The following is a description of a gene set: The presence of skeletal muscular atrophy (which is also known as amyotrophy). studied in species Homo sapiens Human Gene Set: HP_SKELETAL_MUSCLE_ATROPHY Skeletal muscle atrophy, and this is the list of marker genes: POLR3A, NDE1, FLVCR1, ACADM, CAV3, MINPP1, ACTB, DHTKD1, OPA1, POMK, COL6A3 (collagen type VI alpha 3 chain), MYH3, JAG2, FOXP2, BMP1, CEP126, MKKS, PMP22, RBCK1, NPHP1, AMPD2, COG8, HSPB1, CHP1, COL2A1, MT-TE, ERGIC1, PYGM, SCO2, CRPPA, CD59, PHYH, C2orf69, DNM2, AGRN, SH3TC2, SIL1, TBK1, STUB1, BBS7, GYG1, TP53, SBF1, TOE1, MFN2, RNF170, ATAD3A, RNF31, CHRNG, VLDLR, MSTO1, TPM2, LZTFL1, SCAPER, ADSL, ERBB4, HNRNPA1, KIF5A, TBC1D23, SCN4A, KIF1B, BBS12, HK1, GBE1, IDUA, ITPR1, ADK, ARL6, SCYL1, PSMG2, WRN, IFT74, MARS1 (NCBI Gene Id 4141), TTC19, ADSS1, MLIP, MAFB, CADM3, HEXB, GNE, TPI1, MGME1 (NCBI Gene Id 92667), DARS2, WDR81, PLEKHG5, PHKB, PEX7, BBS4, ERLIN1, COMP, ADARB1, TUBB2B, SUCLG1, AR, TBCK, MYH7, SQSTM1, CHRND, BRAF (NCBI Gene Id 673), SLC9A6, CCT5, WNK1, NALCN, NDUFA9, ARSI, CPT1A, PGAP1, SMN2, NBN, SPAST, ITPR3, AK9, ANTXR2, MAG, RXYLT1, MT-ATP8, UNC13A, YY1, ATL3, CHMP2B, ITGA7, SFXN4, MEGF10, UNC45B, ATP8A2, CARS1, LAMB2, DNAJC19, MST1, NDUFA8, KLC2, DHH, SDHD (NCBI Gene Id 91899), PHF6, FHL1, BBS10, NEFH, TIA1, SMCHD1, PHKA1, TCAP, PON1 (paraoxonase 1), ANO5, DMD, WASHC5, IBA57, CYP27A1, VAMP1, CA8, CNTNAP1, MYH14, SDHAF1, RETREG1, PEX5, JPH1, SOX10, REV3L, TRIM2, SDHB, WARS1, DAG1, LIMS2, NEMF (NCBI Gene Id 9147), GIPC1, LMOD3, TRPV4, PYROXD1, NT5C2, SYNE1, SLC46A1, B4GALT7, B4GALNT1, COL6A2, INPP5K, OGDH, OPTN (NCBI Gene Id 337928), DCAF8, DAO, CHRNA1, KRT14, NOTCH2NLC, COL6A1, FLNA, PRPH, SYT2, TOR1AIP1, DNM1L, CEP290, PIP5K1C, FIG4, MYO9A, ATP13A2, IGHMBP2, RAB7A (RAB7A, member RAS oncogene family), MYMK, B3GALNT2 (NCBI Gene Id 148789), NAGA (NCBI Gene Id 4668), PAX3, CDH23, SVBP, BBS1, SNAP25, SLC25A19, FLRT1, FBXL4, DYNC1H1, TIMMDC1, EXOSC3, KDM5C (NCBI Gene Id 8242), MTMR14, RECQL, COLQ, SETX, AFG3L2, BAG3, CD28, ERLIN2, KAT6A, INF2, TFG, COQ2, H4C11, VRK1, TMTC3, TRAPPC11, ATXN2, POLG, CTLA4, LMNA, MTRFR, DOK7 (docking protein 7), POGLUT1, NR3C1, KLHL40, AIFM1, POLRMT, COQ7, B4GAT1, AIMP1, TYMP, NDUFB8, VWA1, CHRNB1, ACTA1, GLT8D1, PON3, VAPB, SLC33A1, CHAT, ZFYVE26, BMP4, FUCA1, PMP2, DPM3 (NCBI Gene Id 54344), COL12A1, SPRTN, SLC52A3, NARS2, MUSK, ASCC1, ERCC6, SDCCAG8 (NCBI Gene Id 10806), ADCY6, FBLN5, SLC5A6, HINT1, KLHL41, SIGMAR1, CPT1C, MPZ, DALRD3, VPS13A, GLE1, VMA21, MRE11, MORC2, CAPN1, BBS2, CUL4B (cullin 4B), GALC, PLXND1, SEMA4D, GAN, ANG, AARS1, TARDBP (TAR DNA binding protein), NUP88 (NCBI Gene Id 4927), SLC25A21, TREM2, PAX7, CHCHD10, PTEN, CNBP, EXOSC9, PUS1, SLC52A2, NEB, SYNE2, SCN5A, SOD1, TNFRSF1B, MME, WDPCP, SALL4, SGCD, RRM2B, SLC39A13, ACADSB, HMGA2, FXN, SGCG, BBIP1, SUCLA2, KDM1A, JAG1, ACTN2, HARS1 (histidyl-tRNA synthetase 1), NIPA1, KRT5, HYCC1, KY, VPS13D, BSCL2, SPART, MYBPC1, SMN1 (NCBI Gene Id 91918), BIN1, CFAP418, POMGNT1, PEX6, SPTBN4, BBS9, ATP1A1, UBAP2L, RILPL1, KBTBD13, MDH2, RAI1, SCYL2, ATP7A, MCCC2, PHKA2, CHN1, ATXN1, HSPB3, SCLT1, TNXB, MTAP, POMT2, LRP12, PFKM, MYMX, MPV17, PIK3R5, ERBB3, PIEZO2, MYOT, PRX, AP1S2 (adaptor related protein complex 1 subunit sigma 2), SLC18A3 (solute carrier family 18 member A3), VCP, NPPA, ASAH1, GJB1, DYSF, DUX4L1, AGTPBP1, UBAP1, NOP56, DUX4, AMPD1, STAT1, MT-TL1, ADAMTS15, CTNS (cystinosin, lysosomal cystine transporter), UBA1, TMEM43, POMT1, CFAP410, PDK3, PNPT1, PIGA, ATCAY (NCBI Gene Id 85300), POLR2A, NDUFA12, LEMD3, HNRNPDL, C9orf72, BVES, RBM28, TTN, GPR35, CAPRIN1 (cell cycle associated protein 1), SDHA, PLOD3, PON2, NDUFS2, GDAP1, POMGNT2, DCTN1, RTN2, TDP1, GBA2, ISCU, PNPLA6, REEP1, BBS5, ERCC8, STIM1, SELENON, FKTN, EGR2, ZBTB20, PFN1, DGUOK, MAGEL2, NEXMIF, SLC12A6, UBQLN2, LTBP4 (latent transforming growth factor beta binding protein 4), SEPTIN9, ABCA1, USP8, SGCA, RNASEH1, ATXN3 (NCBI Gene Id 4287), SLC16A2, FKRP, APTX, FLNC, FITM2, GLB1, LMNB2, WARS2, ATRX, IFT172, AIP, LITAF, FARS2, MECP2, TRIP4, SLC25A1, ENTPD1, FAM111B, CPLANE1, PI4K2A, FUS, YARS2, SACS, BICD2, TUBA1A, PDXK, SPG11, EMD, FRG1, ABHD12, RYR1, TTC8, DNAJB2, SLC5A7, EXOSC8, COG3, TPM3, KIF21A, MB, STAC3, SPTLC2, PTRH2, TGFB1, ARMC5, COG7, INSR, PHKG2, RAPSN, HSPG2, KLHL9, CHRNE, YARS1, CAPN3, C19orf12, PRPS1, TRIM32, SMPD1, KIF1A, ALS2, NDUFAF6, NEK1, TTPA, COL25A1, SLC25A4, TBCD, LAMP2, AHDC1, NGLY1, NDRG1, PLP1, PPARGC1A, KIF1C, PYCR2, STING1, TNR (tenascin R), DNA2, NEU1, CCDC115, COL4A1, DIAPH1, TIMM8A, DNMT3B, PIK3R2, GMPPB, TWNK, RPS6KA3, PRUNE1, TCF4, AGL, LIPE, PHKG1, MYPN, SGCB, SPTLC1, SPTAN1, HMGCR, MKS1, DES, HSPB8, MYOD1, RYR3, TAF15, ANXA11, NAA60, LRP4, PEX10, IFRD1, RRM1, SLC25A46, PLEC, IFT27, SPEG, HNRNPA2B1, FBXO38, NDUFS4, PSMB8, FGD4, CEP19, LRSAM1, SCN9A, ALDH18A1, PNKP, LDB3, ATM, KCNK9, SBF2, HUWE1, SLC7A7, MED25, GNAS, GFPT1, LETM1, SURF1, NEFL, TBCE, COASY, GARS1, COL13A1, ATL1, PNPLA2, ZC4H2, FKBP14, KANSL1, COL7A1, GBF1, USP48, TK2, MAP3K20, TNNT1 (NCBI Gene Id 7138), CYP7B1, COA7, LARGE1, CCNF, GNB4, MATR3, MTMR2, PTRHD1